Given this list of marker genes REEP1, HSPB1, GAN, IFRD1, HSPB8, CRYAB, SPTLC2, MTPAP, ATP6AP2 (ATPase H+ transporting accessory protein 2), FLNC, RUBCN, FBLN5, MYOT, MYH14, PRKCG (protein kinase C gamma), PMP22, FBXO38, HADHA, DES, ATP9A, HADHB, FLRT1, ADSS1, PDK3, PNPLA6, MPV17, IBA57, LDB3, SPTAN1, LMNA, GDAP1, MAG, KLC2, ATL3, FASTKD2, DYNC1H1, DYSF, BICD2, STIM1, here is a description of the gene set: Human Gene Set: HP_HYPOREFLEXIA_OF_LOWER_LIMBS Reduced intensity of muscle tendon reflexes in the lower limbs. Reflexes are elicited by stretching the tendon of a muscle, e.g., by tapping. Hyporeflexia of lower limbs species: Homo sapiens